Given this list of marker genes FTLP3, CISD1, NDUFA10, MT-CO3, DEFB1, TUBB2B, RTL8C, CLCNKB, UQCRC2, COX4I1, ATP5F1D, WSB1, GOT1, PNKD, CYFIP2, NDUFB1, ABLIM1, MT-ATP6, FTL, ACP3, VAMP8, NDUFB6, UQCRFS1, FXYD2, EGFL6, MTATP6P1, ISCU, NDUFS3, ETFB, ATP5F1C, NDUFA6, MINDY2, MRPL41, NDUFB4 (NADH:ubiquinone oxidoreductase subunit B4), MST1P2, FKBP2, CHMP2A, PAPSS2, EIF3K, MGST3, LAMB1, TSTD1, CLDN10, ALDH1A1, MYO6, COX5B, RNPC3, PDHA1, CAPN2, NUDT4, KCNJ1, COA3, APOE, HOXD8, HSBP1 (heat shock factor binding protein 1), NDFIP1, PTGER3, ERBB4, BEX3, MRPS25 (mitochondrial ribosomal protein S25), ARHGAP24, NIPSNAP2, VAV3, ATP5MC3, GPI (glucose-6-phosphate isomerase), MT-ND6, RNF7 (ring finger protein 7), UQCRQ, HOXD9, NDUFB8, ATP5F1E, COX8A, CTSL, UGT8, UQCRB, PAPPA2, MT-RNR2, ATP5MG, SLC12A1, HINT2, DNER, MT-ND4L, ATP5ME, COX5A, UQCRHL, RHOBTB3, NDUFS8, CYSTM1, AHCYL1, CD24, TMEM213, SLIRP, MT-CO1, ESRRG, CXCL12, SDC4, TSPAN12, NDUFA8, REXO2, ACADVL, IVNS1ABP, NDUFS2, SULT1C2 (sulfotransferase family 1C member 2), CHCHD10, ATP6V0E1, CYCS, PIK3R1, UCHL1, PGK1, MICOS10, ECI1 (NCBI Gene Id 1632), MRPS6, ESD, NDUFA3, BEX2 (NCBI Gene Id 84707), DECR1, MPC1, ITPRID2, MICOS13, ASAH1 (NCBI Gene Id 79795), PHB1, CKB, NDUFS6, GHITM, NDUFB5, IDH2, CA12, POLR2L, CLDN19, COMMD6, MT-ND5, SLC2A11, AKAP9, MT-ND2, NDUFC1, POU3F3, ATP1A1, MT-ND1, FAM162A, LDHB, MT-ND4, NARS1, KCNJ16, COX6C, GSTK1, COL18A1, GABARAPL2, NDUFA5, UMOD, CPNE3, SERF2, COBLL1, IRX2, ATP5F1A, MECOM, NEFL, ENO1, KRT10, NDUFA2, ATP5PO (NCBI Gene Id 539), LAMTOR5, PRDX5, MAL, COX6B1, ATP5MC1, UQCRC1, MT-RNR1, UQCR11, DMAC1, ATP5PF, COX20, TMEM72, NDUFV1, MAGEF1, CYP1B1, NDUFB9, PRDX3, ATP6V0B, ATP5PD, TCEAL4, SMDT1, SLC5A3, ALDOA, AK3, NDUFB7, SMIM24, PLEKHB2, ANK3, GNG5, HSPE1, UQCRH, ATP1B3, MT-CO2, ATRAID, TMEM59, DCDC2, NEDD4L, KNG1, AFP, HIGD2A, MST1L, RBM47, TFCP2L1, S100A6, ITM2B, ATP6AP1, MEST, MT-ND3, TFAP2B, COL6A1, MRPL33, ITM2C, CDH16, TPI1, APLP2, IGFBP7, PKM, MT-ATP8, NDUFS7, AFG3L2, PTH1R, TOMM7, AURKAIP1, DUSP9, SLC9A3-OT1, MT-CYB, MTURN, AKIRIN1, MPC2, VDAC1, ATP5F1B, ATP6AP2, ATP5MJ, ATP1B1, COX7C, ANXA11, CPM, NEAT1, NDUFC2, SLC25A5, HSPA9, PKP4, CLCN5, CRYL1, SUCLG1, CYC1 (NCBI Gene Id 1537), TMBIM6, COX7B, EPCAM, ATP5MK, CYS1, CLDN16 (claudin 16), COX7A2, CD63, TRIM2, UQCR10, MUC1, SLC25A4, MDH1, IMMT, ATP5PB, SLC25A6, CTDSPL, SPP1, DZIP1, XPA, COX6A1, SPINT2, NPC2, NDUFA1, GSTM3, NDUFB2, ID2, NDUFA4, MRPS5, PEBP1, here is a description of the gene set: from publication Menon R, Otto EA, Kokoruda A, Zhou J, Zhang Z, Yoon E, Chen YC, Troyanskaya O, Spence JR, Kretzler M, Cebrián C (PMID 30166318) studied in species Homo sapiens Human Gene Set: MENON_FETAL_KIDNEY_7_LOOPOF_HENLE_CELLS_DISTAL